The following is a description of a gene set: from publication Cui A, Huang T, Li S, Ma A, Pérez JL, Sander C, Keskin DB, Wu CJ, Fraenkel E, Hacohen N (PMID 38057668) Mouse Gene Set: CUI_T_CELL_GD_FASL_RESPONSE_DN studied in species Mus musculus Genes negatively differentially expressed in cell type: γδ T cell upon treatment with cytokine: FasL in mouse lymph nodes in vivo. Cytokines mediate cell-cell communication in the immune system and represent important therapeutic targets. A myriad of studies have highlighted their central role in immune function, yet we lack a global view of the cellular responses of each immune cell type to each cytokine. To address this gap, the authors created the Immune Dictionary, a compendium of single-cell transcriptomic profiles of more than 17 immune cell types in response to each of 86 cytokines (>1,400 cytokine-cell type combinations) in mouse lymph nodes in vivo. A cytokine-centric view of the dictionary revealed that most cytokines induce highly cell-type-specific responses. For example, the inflammatory cytokine interleukin-1β induces distinct gene programmes in almost every cell type. A cell-type-centric view of the dictionary identified more than 66 cytokine-driven cellular polarization states across immune cell types, including previously uncharacterized states such as an interleukin-18-induced polyfunctional natural killer cell state., and this is the list of marker genes: Nr4a1, Jun, Dusp1, Junb (jun B proto-oncogene), Hspa1a, Sik1, Fos, Pnrc1, Fosb (NCBI Gene Id 14282), Btg2, Hspa1b, Ubb, Ppp1r15a, Klf6, Zfp36l2, Rgs1, Jund, Ubc, Klf2, Rhob